The following is a description of a gene set: Mouse Gene Set: CUI_MIGDC_IL7_RESPONSE_UP Genes positively differentially expressed in cell type: MigDC (migratory dendritic cell) upon treatment with cytokine: IL-7 in mouse lymph nodes in vivo. from publication Cui A, Huang T, Li S, Ma A, Pérez JL, Sander C, Keskin DB, Wu CJ, Fraenkel E, Hacohen N (PMID 38057668) Cytokines mediate cell-cell communication in the immune system and represent important therapeutic targets. A myriad of studies have highlighted their central role in immune function, yet we lack a global view of the cellular responses of each immune cell type to each cytokine. To address this gap, the authors created the Immune Dictionary, a compendium of single-cell transcriptomic profiles of more than 17 immune cell types in response to each of 86 cytokines (>1,400 cytokine-cell type combinations) in mouse lymph nodes in vivo. A cytokine-centric view of the dictionary revealed that most cytokines induce highly cell-type-specific responses. For example, the inflammatory cytokine interleukin-1β induces distinct gene programmes in almost every cell type. A cell-type-centric view of the dictionary identified more than 66 cytokine-driven cellular polarization states across immune cell types, including previously uncharacterized states such as an interleukin-18-induced polyfunctional natural killer cell state. species: Mus musculus, and this is the list of marker genes: Ccnd2, Cdkn1a (NCBI Gene Id 12575), Cfl1, Pfn1, Ccl17, Arpc1b, Eif4a1, Syngr2